Given this list of marker genes ARHGDIA, ARHGAP24, CD2AP, TBC1D8B, DAAM2, NUP85, PAX2, GAPVD1, PLCE1, MAGI2, ANKFY1, CRB2, PTPRO (NCBI Gene Id 5800), NUP205, EMP2, TRPC6, NUP93, MYO1E, APOL1, NUP160, INF2, NUP37 (nucleoporin 37), NPHS1 (NPHS1 adhesion molecule, nephrin), ANLN, ACTN4, NUP133, NPHS2, COL4A3, WT1, NUP107, COQ8B, here is a description of the gene set: Foamy urine Urine has an increased amount of frothy fine bubbles. species: Homo sapiens Human Gene Set: HP_FOAMY_URINE